The following is a description of a gene set: from publication Cui A, Huang T, Li S, Ma A, Pérez JL, Sander C, Keskin DB, Wu CJ, Fraenkel E, Hacohen N (PMID 38057668) Genes positively differentially expressed in cell type: NK cell upon treatment with cytokine: IL-18 in mouse lymph nodes in vivo. Cytokines mediate cell-cell communication in the immune system and represent important therapeutic targets. A myriad of studies have highlighted their central role in immune function, yet we lack a global view of the cellular responses of each immune cell type to each cytokine. To address this gap, the authors created the Immune Dictionary, a compendium of single-cell transcriptomic profiles of more than 17 immune cell types in response to each of 86 cytokines (>1,400 cytokine-cell type combinations) in mouse lymph nodes in vivo. A cytokine-centric view of the dictionary revealed that most cytokines induce highly cell-type-specific responses. For example, the inflammatory cytokine interleukin-1β induces distinct gene programmes in almost every cell type. A cell-type-centric view of the dictionary identified more than 66 cytokine-driven cellular polarization states across immune cell types, including previously uncharacterized states such as an interleukin-18-induced polyfunctional natural killer cell state. Mouse Gene Set: CUI_NK_CELL_IL18_RESPONSE_UP studied in species Mus musculus, and this is the list of marker genes: Pfkl, Slc16a1, Nip7, Eif1ax, Nop58, Cope, Nat10, Bri3bp, Eif3d (eukaryotic translation initiation factor 3, subunit D), Ube2v2 (NCBI Gene Id 98028), Nfkbiz, Bud23, Znhit6, Pop7, Tmem167, Usp36, Tnpo3, Slc2a6, Rars1, Lad1 (ladinin), Hnrnpm, Tcea1, Amd1, Mrps6, Snrpe, Ipo5, Klrg1, Top1, Gmps, Pmpca, Myo1g, Clptm1l, Dhps, Rpp38, Mdh2, Rcc2, Elovl1, Phb2, Niban1, Furin, Sbno1, Kpnb1, Dnaja3, Rpf2, Ydjc, Hspa8, Adam8 (a disintegrin and metallopeptidase domain 8), Trmt6, Wdr77 (NCBI Gene Id 97079), Wdr5, Psat1, Polr2f, Gtf2f2, Nfs1, Tial1, Sdhd, Mix23, Heatr1, Tmsb15b1, Tmem248, Srsf6, Pus7, Serbp1, Pa2g4, Srrm1, Snhg12, Phgdh, Skp1, Aen, Nol12, Hnrnpdl, Cd320, Nmt1, Cd82, Mrpl38 (NCBI Gene Id 97773, mitochondrial ribosomal protein L38), Tcerg1, Snrk, Nop14, Cd52, Gadd45gip1, Eny2, Eef1akmt4, Cnih4, Zmiz2, Srsf3, Pbdc1, Pkm, Hsph1, Lsm12, Bysl, Psmc5, Ccdc86, U2af1, Got2, Tnfsf4 (NCBI Gene Id 226545), Manf, Ddx1, Pus7l, Gde1 (glycerophosphodiester phosphodiesterase 1), Sigmar1, Slc25a32, Fxn, Api5, Utp25, Psmg2, Cycs, Carnmt1, Dimt1 (NCBI Gene Id 66254), Gadd45b, Pim1 (NCBI Gene Id 18712), Hmgn1, Icam1, Septin11, Dnajc11, Uchl5, Plaa, Umps, Gphn, Ppia, Ndufab1, Dnajb11, Sf3a1, Ndufa4, Pfdn6, Cct7, Ufm1, Uck2, Polr1f, Orc2 (NCBI Gene Id 98596), Tufm, Mrps28, Pno1, Gcn1, Nop56, Ube2n, Prkar2a, Aimp2, Tmed9 (NCBI Gene Id 67511), Hspa4, Srsf2, Dnaja2, Atp5mk, Atp5pb, Rpp30, Pim2, Zfx, Sac3d1, Adsl, Bcl2l11, Guk1, Ndufs7, Ppp1r11, Fabp5, Cox7b, Spcs2, Tcp1, Kpna3, Nup43, Dph6, Utp20 (UTP20 small subunit processome component), Ran, Mrfap1, Fbl, Sf3a2, Tfap4, Shmt1, Thop1, Eif2a, Naca, Clec2d, Hacd3, Naa10, Mrps5, Psmc1, Exosc2, Spout1, Tars1, Fastkd2, Abcc1, Tkt (transketolase), Dkc1, Tuba1b, Trap1, Lrrc59, Ddx18, Trmt1, Hspa5, Nme1, Rpn1, Hspa9, Rwdd4a, Rbm19, Mrpl35, Ssb, Larp4, Ctps1, Tmed2, Hnrnpa3, Ntmt1, Dut, Gtpbp4, Pycr2, Trmt61a, Ube2e1, Snrpd3, Cpsf2, Ybx1 (NCBI Gene Id 97156), Tomm20, Usp14, Larp1, Slc25a39, Kmt2a, Pabpc1, Mrpl28, Romo1, Sdc4, Srsf7, Txn2, Ddx39a, Ssr2, Polr1g, Rif1, Ncl, Mvb12a, Mydgf (NCBI Gene Id 28106), Hsd17b12, Prelid3b, Ldha, Cdkn2aipnl, Mthfd2, Ptges3, Jade2, Ubfd1, Dad1, Xrcc6, Tbl1x, Rpf1, Wdr55, Lyar, Afg2a, Emc6, Tsen54, Mrpl54, Myc, Mrpl11 (NCBI Gene Id 66419), Rbx1, Fam98a (NCBI Gene Id 72722), Mrps14, Nfkb1, Tubb4b, Fcf1, Parp1, Epop, Irf8 (interferon regulatory factor 8), Cct4, Etf1, BC035044, Traf1, Cd44, Pdrg1, Mogs (mannosyl-oligosaccharide glucosidase), Atad1, Zranb2, Txndc17, Dtymk, Pwp1, Ero1a, Lig3, Mrpl57, Tmem11, Rrp1b (ribosomal RNA processing 1B), Syncrip, Pin1, Purb, Bcas2, Ndufa12, Utp4, Psma5, Eef1d, Zfp593, Eif3a, Glrx3, Alg3, Timm50, Tnfrsf9, Hnrnpr, Eif4a1, Hspbp1, Timm17a, Nmd3, Gps1, Yars2, Hk2, Mrps10, Cox5a, Ube3c, Rbm28, Mesd, Psmg1, Caprin1, Adora2a, Prmt7, Tuba1c, Memo1, Fasn, Ndufaf8, Phb1, Utf1, Ehd1, Nudt5, Cad, Sf3b5, Psmb7, Rangrf, Tbl3, Exosc4, Pgls, Galk1, Eif3m, Exosc1 (NCBI Gene Id 67682), Uqcr10, Rexo2, Ppp2r2a, Eif6 (NCBI Gene Id 98777), Mfsd14a, Idh3a, Ksr1, Dnlz, Psmd11, Polr1d, Aasdhppt, Eci1, Ccl3, Ostc, Smu1, Trp53, Hnrnpa0, Slc6a6, Dlat, Relb, Med24, Dnajc21, Sap18 (NCBI Gene Id 52619), Wars1, Ncf4, Ddx21, Bcl2a1b (B cell leukemia/lymphoma 2 related protein A1b), Psme3, Naa15, Ubl4a, Prkrip1, Exosc8, Ube2f, Wdr36, Cox19, Mrps7, Ppp1r14b, Exosc5, Cd70, Thoc1, Trnau1ap, Ikbke, Brix1, Cdca7, Paics, Cox7c, Kcnq1ot1, Tmem185b, Rilpl2, Nars1, Bcap29, Smyd5 (SET and MYND domain containing 5), Hnrnpc, Milr1, Usp10, Smyd2, Timm8a1, Rbm8a (NCBI Gene Id 98227), Tnni1 (NCBI Gene Id 98425), Cinp, Stat5a, Npm3, H3f3a, Rnf126, Lsm7, Pou2f2, Vdac2, Eif3b, Thoc3, Sec11c, Sec61b, Ncr1, Mrps26, Arfrp1, Lrpprc, Tent4a, Dusp12, Txnl1, Mthfd1, Ifrd2, Ddx54, Exosc3, Grap, Eif4g1, Taf1d, Noc2l, U2surp, Ptger4, Nap1l1, Ddost, Suclg2, Tomm5, Akr1b1 (aldo-keto reductase family 1 member B), Mettl16, Dda1, Hint1, Naa25, Zfp263, Bzw2, Thoc6, Med21, Cct8 (NCBI Gene Id 12469), Smarce1, Wdr46, Rad50, Eef1e1, Rbm17, Itsn1, Snrpa1, Anp32b, Fpgs, Mat2a, Nadk, Nsun5, Prpf40a, Pomp, Nap1l4, Pam16, Surf2, Pak1ip1, Ifng, Stk16, Eif5, Xcl1, Sdad1, Riox1 (NCBI Gene Id 71952), Prdx6, Uqcc4, Rsl24d1, Rrp8, Tfrc, Pfas, Mrps17, Qdpr, Smarca4, Emg1, Bhlhe40, Bax, Hras, Dctd, Utp6, Nup205, Atp2a2, Psma2, Cdc37, Tmem147, Mtap, Drg2, Tcf7, Sod2 (superoxide dismutase 2, mitochondrial), Pepd, Ndufaf4, Apex1, Surf6, Grwd1, Eif3j1, Lcp1 (lymphocyte cytosolic protein 1), Strap, Snrpf, Cdk7, Hsp90aa1 (NCBI Gene Id 15524), Nudc, Psmd3, Tmem70, Ssr4, Banf1, Eif4e2, Ndufc2 (NADH:ubiquinone oxidoreductase subunit C2), Agpat5, Parl, Skil, Bzw1, H13, Tex30, Tomm22, Pycr3, Ruvbl1, Hnrnpu, Clpp (NCBI Gene Id 53895), Ubap2, Tlcd1, Stx6, Bola3, Psma7, Atic, Impdh2, Heatr3, Eif1ad, Knop1 (lysine rich nucleolar protein 1), Tspan4, Magoh, Batf, Noc4l (NCBI Gene Id 231606), Hnrnpf, Dctpp1, Erh, Slirp, Eif2s1, Cs, Alkbh1, Cish (cytokine inducible SH2-containing protein), Polr2e, Pelp1, Pole3, Mak16, Gar1, Nolc1, Cct3, Arl1, Tsr1, Timm8b, Ndufb2, Adap1, Btf3, Eif3l, Pdxp, Snhg6, Ywhag, Pigu, Bop1, Mrpl21 (NCBI Gene Id 353242), Atp5mc3, Set, Hprt1, Tma16, Pum1, Morf4l2, Gnl3, Khdc1a, Fubp1, Ppp5c, Dohh, Ddx24, Kmt5a (lysine methyltransferase 5A), Nop2, Cers2, Rbm25, Ccdc50, Mgll, Prdx3, Rrp9, Ncbp2, Txndc9, Eif5a, Cnbp, Nol11, Atp5mf, Tnfsf14, Hspe1, Uchl3, Pfdn2, Trim28, Unc93b1, Birc3, Gnl2, Sf3b3, Pals2, Rbbp7, Cyc1, Ddx10, Psmb6, Ywhae, Ybx3, Zc3h15, Srsf10, Adh5, Naa20, Dph3, Mir155hg, Ftsj3, Aimp1, St13 (NCBI Gene Id 70356), Npepl1, Gapvd1, Fas, Mrps24, Qtrt2, M6pr, Sdhaf1, Ube2i, Denr, Tnip1, Atp5f1d, Ppid, Ccl1, Lsg1, Ipo7, Szrd1, Prmt1, Naa16, Ewsr1, Htra2, Sae1, Ttc27, Tmem97, Ifi211, Pdcd1lg2, Carm1, Snx3, Pprc1, Mdn1, Ddb1, Uqcrq, Eif3c, Nol8, Psmb2, Ndufs8, Nol9, Atp5pf, Tpi1, Suclg1, Isy1, Dok2, Tgs1, Hnrnpa2b1, Mrpl23, Sms, Kansl2, Txnl4a, Gsto1, Tuba4a, Mrpl12, Rrp1, Thoc2l, Rae1, Mbd3, Cfdp1, Mrpl52, Chchd1, Pop1, Srm, Nfkbib, Vdac1, Ppil1 (NCBI Gene Id 68816), Lmnb2, Eef1g, Nom1, Rnps1, Ddx27, Selenoi, Htatsf1, Gpat4, Tesc, Stt3a, Dtwd1, Eif1a, Cd83, Gpr18, Hnrnpa1, Pum3, Mrps18b, Hspd1, Asap1, Hars1, H2ax, Xpot (NCBI Gene Id 97647), Psmd12, Pop5, Nubp1, Cul3, Aifm1, Polr3d, Iars1, Pold2, Snu13, Pfdn4, Grpel1, Zpr1, Pdcd11, Mrpl17, Rcl1, Lap3, Ppan, Nol6, Cluh, Nop16, Lars1, Atad3a, Sema6d, Tfam, Kit, Btbd1, Nup54 (NCBI Gene Id 269113, nucleoporin 54), Snrpd2, Wdr3, Pebp1, Uqcrb, Hnrnpd, Mrps12, Utp14a, Zfp706, Gpr65 (NCBI Gene Id 14744), Tcof1, Stip1, Psma3, Slc39a6, Cops7a, Higd1a, Abhd11, Slc19a1, Bcor, Selenos, Ssrp1, Eif4a3, Fyttd1, Llph, Abcf2, Timm44, Gzmc, Vcp, Sumo2, Farsb, Cacybp, Bst2, Pim3, Isyna1, Prmt3, Samm50, Ranbp1, Nudcd2, Pvt1, Nol7, Hnrnpab, Exosc7, Gadd45g, Sec61g, Cdc34 (NCBI Gene Id 216150), Glrx5, C1qbp, Psmd1, Aatf, Qtrt1, Dnttip2, Fam136a, Anapc15, Dcaf1 (DDB1 and CUL4 associated factor 1), Ltv1, Kdm6b, Eprs1, Dcun1d5, Pisd, Kdm2b, U2af2, Snrpc, Phf5a (NCBI Gene Id 68479), Utp11, Ivns1abp, Polr1e, Sinhcaf, Aprt, Eef2kmt, Slc39a7, Mthfd1l, Ilf2, Timm9, Odc1, Krtcap2, Kdelr2, Slc25a5, Cks2, Psma4, Esf1, Ndufa5, Aven, Ccdc115, Rpia, Tmem158, Mrps2, Bcl2l1, Bola2, Pdap1, Ccdc184, Gspt1, Rnaseh1, Nsfl1c, Gars1, Ifrd1, Eif5b, Rbmxl1, Polr3h, Polr2j, Vars1, Stk39, Snrpa, Ppat, Ola1, Lman1, Pes1, Bcl7c (B cell CLL/lymphoma 7C), Stap1, Tfdp1, Trub1 (NCBI Gene Id 98137), Rpp40, Slc7a5, Hsp90ab1, Rrp7a, Nup62, Polr1a, Zfp106, Adk, Rel, Sar1b, Utp15, Eloc, Polr2h, St6galnac4, Cyba, Rangap1, Mettl1, Cct2, Ythdf2, Zc3h12a, Ppie, Hyou1, Nhp2, Ak2, Pusl1, Thumpd1, Dis3, Mtrr, Bag2, Aldoa, Abcf1, Ahcyl2, Jpt1 (NCBI Gene Id 15374), Uqcrc2, Pdia6, Slc35b1, Ube2s, Abce1, Txlng, Pole4, Eif4e, Ruvbl2, Pdia3, Ciao2b, Npm1, Abitram, Nampt, Ndufb4, Chchd4, Prdx1, Chrac1, Cmtm7, Sem1, Tsg101, Aebp1, Nelfe, Mphosph10, Jak2, Fkbp4, Klhdc4, Mrpl42, Polr2l, Comtd1, Cdv3, Tardbp, Ubtf (upstream binding transcription factor, RNA polymerase I), Ddx56 (NCBI Gene Id 68057), Cops6, Calr, Mrpl15, Srrm2, Imp4, Nomo1, Ppa1, Txnrd3 (NCBI Gene Id 57907), Slc39a14, Mrpl2, Ppig, Tmem33 (NCBI Gene Id 78493), Stoml2, Pdcd5, Tm9sf4, Adss1, Ciao2a, Fam162a, Tsen2, Alyref, Mrpl20, Metap2, Psma6, Ddx49, Ier3ip1, Uqcr11, Uap1, Rpp14, Naa50, Rcc1, Nle1, Gcsh, Utp23 (NCBI Gene Id 78581), Slc25a3, Gemin5, Slc7a1, Yrdc, Gzmb, Sco2, Nr2c2ap, Serpine2, Prrc2c, Rabggtb, Nfkb2, Mrpl16, Tsfm, Eif4h, Luc7l, Psmd6, Wdr12, Csnk2a2, Mtdh, Nol10, Naf1, Srsf11, Psmb5, Cetn3, Actn4, Cebpz, Ung (uracil DNA glycosylase), Mrps33, Med29, G3bp1, Cmss1, Eif3g, Rrp15 (ribosomal RNA processing 15 homolog), Shmt2 (serine hydroxymethyltransferase 2 (mitochondrial)), Tomm40, Eif2s2, Rcc1l, Rsl1d1, Gnpnat1, Polr1b, Gpn1, Sfpq, Ern1 (NCBI Gene Id 97745), Gls, Usp50 (NCBI Gene Id 76616), Cdk4, Nefh, Mrpl51, Dennd5a, Thyn1, Kars1, Kti12, Ppp1cb, Rwdd1, Wdr4, Pgam1, Il2ra, Pabpc4, Txn1, Ebna1bp2, Ppm1g (NCBI Gene Id 14208), Crtam, Znrd2, Srsf9, Alg5, Rbm26, Nucks1, Ccdc59, Osgep, Atp5mc1, Srprb, Psme2, Canx, Mia2, Atp5f1b, Ciapin1, Mif, Fkbp1a, Ndufb6 (NADH:ubiquinone oxidoreductase subunit B6), Nrros, Ubap2l, Ptma, Mrto4, Edf1, Dus1l, Elavl1, Morc2a, Cd69, Ly6e, Jpt2, Bcl2a1d, Krr1, Utp18, Telo2, Wdr75, Mrpl50, Snrnp70 (NCBI Gene Id 97422), Mecr, Emc4, Tmem109, Ptcd2, Itgb1, Prmt5, Nsun2, Rbm3, Farsa, Cd72, Acbd6 (NCBI Gene Id 72482), Las1l, Serp1, Hgh1, Ipo4, Tmed5, Snrpd1, Pinx1 (NCBI Gene Id 72400), Mcrip2, Mrpl36, Psmd7, Hirip3, Clns1a, Asb2, Cct5, Gtf2h5, Nfkbia, Gart, Serpina3g, Dnajc2, Wdr18, Cstf1, Actl6a, Wdr83os, Rrp12, Ahsa1, Ccdc124, Rrs1, Rgs16, Anp32e, Tbca, Pgk1, Pcbp1 (poly(rC) binding protein 1), Cdk6, Jagn1, Nedd8, Syce2, Cops5, Dnajc8, Timm10, Prpf31, Smarcc1, Chd1, Timm13, Pwp2, Tsr2, Gpatch4, Ssbp1, Noa1, Prpf19, Elp5, Psmc2, Csf2, Uqcc2, Wdr43, Drg1, Sfxn1, Eif2b1, Snd1, Trmt10c, Polr2k, Slc29a1, Obi1, Ptrhd1, Pcna, Mrpl32, Tmem238, Lsm2, Prps1, Magohb, Nus1, Mybbp1a, Rab8b, Tgif1, Nob1, Tfeb, Dus2, Pitrm1, Imp3, Nifk, Bccip, Ak6, Lsm3, Eed, Eif2s3x, Hdgf, Psmc4, Eef1b2, Skic8 (NCBI Gene Id 93803), Eif3i, Psme1, Tomm70a, Otulin, Galnt1, Pla2g12a, Taf10, Macir, Ndufs6, Snrpb, Tagap, Atf4, Champ1, Cxcl9 (NCBI Gene Id 17329), Psmb3, Nufip1, Mrpl19, Lsm6, Smn1, Nop10